The following is a description of a gene set: studied in species Mus musculus Any process that stops, prevents, or reduces the frequency, rate, or extent of myeloid leukocyte differentiation. Mouse Gene Set: GOBP_NEGATIVE_REGULATION_OF_MYELOID_LEUKOCYTE_DIFFERENTIATION, and this is the list of marker genes: Ifnb1, Pilrb1, Trib1, Lrrc17, Gpr137, Ctnnb1, Tmem178, Cldn18, Pira1, Rara, Tnfrsf11b, Hoxa7, Qki, Gpr137b, Fbn1, Lyn, Apcs, Ceacam1, Tjp2, Nf1, Erfe, Ltf, Adipoq, Cdk6, Fbxw7, Bmyc, Tcta, Mafb, Gpr55, Il4, Clec2i, Lilrb4b, Ifng, Pira12, Tob2, Clec2d, Myc, Cul4a, C1qc, Zfpm1, Inpp4b, Tnfaip6, Prdm16, Gpr68, Runx1, Nme2, Ccl3 (NCBI Gene Id 20302), Clec2g, Inpp5d, Zbtb46, Sfrp1, Fstl3, Lilrb4a, Pik3r1, Iapp, Cartpt, Nme1, Pias3, Ubash3b, Thoc5, Ptpn2, Gata2